Given this list of marker genes HR, PERP, LMNA, SNRPE, IL2RA, DSP, VDR, AHSG, TRPV3, PKP1, AIRE, here is a description of the gene set: Alopecia universalis Loss of all hair on the entire body. studied in species Homo sapiens Human Gene Set: HP_ALOPECIA_UNIVERSALIS